The following is a description of a gene set: studied in species Mus musculus Activation of caspases through apoptosome-mediated cleavage Mouse Gene Set: REACTOME_ACTIVATION_OF_CASPASES_THROUGH_APOPTOSOME_MEDIATED_CLEAVAGE, and this is the list of marker genes: Apaf1, Casp9, Cycs, Gm10053 (predicted gene 10053), Casp7, Xiap, Casp3